Given this list of marker genes Nlrp1b, Scarb1, Asgr1, Trim12c, Pglyrp1, Dhx16, Fcnb, Pglyrp3, Tlr2, Nlrp6, Clec4d, Aim2, Ptafr, Pycard, Clec4b1, Cd209e, Clec4a4, Cd14, Fcer2a, Trim30c, Tlr5, Trim30d, Tlr9 (toll-like receptor 9), Fcna, Clec10a, Tlr4, Klrh1 (NCBI Gene Id 232415), Ly96, Cd209f, Clec4a1, Cd207, Clec4n, Clec4g, Cd209b, Nod1, Nod2, Clec4b2, Mgl2, Cd209a, Clec7a, Pglyrp2, Trim12a, Ifih1, Tlr7, Trim30a, Tlr8, Clec4e, Pglyrp4, Tlr3, Asgr2, Clec4a3, Colec12, Rigi, Cd209g, Trim30b, Clec4a2, Clec4f, Trim5, Dmbt1, Nlrp1a, Clec12a, Cd209c, Cd36, Cd209d, here is a description of the gene set: Mouse Gene Set: GOMF_PATTERN_RECOGNITION_RECEPTOR_ACTIVITY Combining with a pathogen-associated molecular pattern (PAMP), a structure conserved among microbial species to initiate an innate immune response. species: Mus musculus